The following is a description of a gene set: Genes having at least one occurrence of the highly conserved motif M169 TTTNNANAGCYR in the regions spanning 4 kb centered on their transcription starting sites. The motif does not match any known transcription factor binding site. Human Gene Set: TTTNNANAGCYR_UNKNOWN Comprehensive identification of all functional elements encoded in the human genome is a fundamental need in biomedical research. Here, we present a comparative analysis of the human, mouse, rat and dog genomes to create a systematic catalogue of common regulatory motifs in promoters and 3' untranslated regions (3' UTRs). The promoter analysis yields 174 candidate motifs, including most previously known transcription-factor binding sites and 105 new motifs. The 3'-UTR analysis yields 106 motifs likely to be involved in post-transcriptional regulation. Nearly one-half are associated with microRNAs (miRNAs), leading to the discovery of many new miRNA genes and their likely target genes. Our results suggest that previous estimates of the number of human miRNA genes were low, and that miRNAs regulate at least 20% of human genes. The overall results provide a systematic view of gene regulation in the human, which will be refined as additional mammalian genomes become available. from publication Xie X, Lu J, Kulbokas EJ, Golub TR, Mootha V, Lindblad-Toh K, Lander ES, Kellis M (PMID 15735639) studied in species Homo sapiens, and this is the list of marker genes: CA7, CDH16, CYP51A1, MXI1, H1-6, PLAAT1, RUNX1T1, H2BC3, H2BC7, H3C10, CHD4, KCNIP4, USP47, PPP3CA, H1-5, H2AC1, FGF17, MYH2, ID4, LIN28A, KMT5A, NSMCE3, SLC35A2, PRKCQ, H3C1, RANGAP1, GPM6B, H3C3, ZNF710, H2AC6, MTSS1, H1-2, DHRS3, TCERG1L, KCNK12, H2AC25, H2BC15, H2AC16, NRP1, PDS5A, CPNE1, INPPL1, H3C2, H2BC4, CLDN2, RGN, AOC2, H1-4, ATXN7L2, DNAJB8, CNN1, CLDN10, H2BC17, DSC1, SLC12A2, H2BC9, H2AC21, H2BC21, CACNG2, RNF44, AMOT, H2BC12, GRK5, NAP1L5, H2BC5, H2AC8, CELA3A, H2AC7, H2BC11, BLNK, KLHL41, SERPINA7, H2BC6, AGTR2, H2BC26, H2BC8, SMO, H4C1, DGKG, SLC6A1, MEIS1, BMPR2, OLR1, H3C4, HOXB6 (homeobox B6), H3-4, H2AC17, RASAL2, TRAF3IP2, H2BC1, E2F3, H2BC13, TDRD5, USP34, SLC6A13, PPP2R2B, H2AC11, ONECUT2, SDHAF3, H1-1, H2AC20, OTP, FOXP1, ARAP2, FGD4, FBXO21, ETS1, HOXB4, H2AC15, H2AC12, SPRED1 (NCBI Gene Id 161742), NDRG3 (NCBI Gene Id 64401), NFATC1, LIMA1, USP46, CNTLN, TGIF1, H3C12, NRAP, DCDC1, TCF4, LHX2, H2AC13, TBXAS1, NLRC3, STARD13, H1-3, H2AC4, EID1, CAST, SLC10A2, DPT, H3C7